The following is a description of a gene set: Mouse Gene Set: GOBP_VIRAL_TRANSLATIONAL_TERMINATION_REINITIATION studied in species Mus musculus A process which occurs as part of viral mRNA translation which allows expression of a downstream open reading frame (ORF) in a dicistronic mRNA. In this process, ribosomes translate the upstream ORF but following termination, a proportion of 40S subunits remain tethered to the mRNA and go on to re-initiate translation at the start codon of the downstream ORF., and this is the list of marker genes: Eif3b, Eif3g (NCBI Gene Id 53356), Eif3d, Eif3a, Eif3l